Given this list of marker genes SIN3A, RBBP4, CSNK2A1, ING2, SAP130, SUDS3, HDAC1, SAP30, SAP30L, BRMS1L, HDAC2, ARID4B, ING1, PHF12, SIN3B, BRMS1, MORF4L1, ARID4A, OGT, SINHCAF, RBBP7, TET1, here is a description of the gene set: studied in species Homo sapiens Any of a number of evolutionarily conserved histone deacetylase complexes (HDACs) containing a core consisting of a paired amphipathic helix motif protein (e.g. Sin3p in S. cerevisiae, Pst1 in S. pombe or Sin3A in mammals) at least one class I histone deacetylase (e.g. Rpd3p in S. cerevisiae, Clr6 in S. pombe, or HDAC1 and HDAC2 in mammals), and at least one WD40 repeat protein (e.g. Ume1p in S. cerevisiae, Prw1 in S. pombe, or RbAp46 and RbAp48 in mammals). These complexes also contain a variable number of other proteins that direct histone binding, DNA binding, or add other functionality to the complex. Human Gene Set: GOCC_SIN3_TYPE_COMPLEX